Given this list of marker genes BAK1, DPYSL4, KRT7, PHF13, CCNA1 (cyclin A1), MFHAS1, WWOX, CFL1, HARS1, DTNB, CACNA1D, SEMA7A, CXCL9, ZNF112, CAPN2, FDX1, MYOF, PIAS3, PSMA5, PHGDH, SLC4A4, ACKR2, CYP1A1, MECP2, IFIT2, SLIRP, KDM5D, NAA30, GBE1, PRG2, RECQL5, NDUFS7, SRXN1, PSMB8, ANGPTL2, UNK, GPA33, CPLX4, IAH1, PARP12, CCNA2 (NCBI Gene Id 890), CHDH, ATF3, GUCD1, REPS1, KCNJ12, GDI2, BLOC1S5, DDIT3, SNRNP27, NSMF, EHBP1 (EH domain binding protein 1), CCDC71L, ST6GALNAC6, UBQLN2, SEMA3B, SLA2, DYNLT1, CD200, UQCRFS1, PHLDA2, NCOR1, LAT, ZBTB2, CYP27B1, TRIP11, KLHDC4, CNOT4, GATC, NECAB3, SCNN1A, IER3IP1, RFC2, RPS9, STAT5A, CCT2, PLXND1, RBM10, OSBPL11, RXRB, SOCS2, IREB2, LZTFL1, VRK2, C11orf68, IL10RB, IRF8, USP38 (NCBI Gene Id 84640), SYT9, COL4A2, MYD88, CX3CL1, ARHGAP35, EIF1B, IER5, ABCA2, ADIPOR2, DNAJC1, RP9, C19orf25, PTPRJ, SMOX, SPAG5 (sperm associated antigen 5), UBE2D2, GDNF, TBL1X, SLC30A1, MGA, SHFL, ZNF131, CDKN2A, TIPARP, LMNB2, DRAM2, ZNF605, ARSI, METAP2, TTC39C, ACTN1, CPSF2, FBXO11, PARK7, CTDNEP1, AUTS2, ATF6, MTARC2, IQSEC1, CRYAA, OGG1, BPGM, KIF21B, SFN, WASHC2A, TLN1, GAPDHS, OLR1, NID1, SUGP1, SLC28A2, PAGR1, TAF4, CLCN5, ARHGEF2, ADRB2, SATB2, ZMYM1, GPANK1, BSN (NCBI Gene Id 90068), RAP2A, DHX15, CEP250 (centrosomal protein 250), RPL12, MAFG, NPY1R, PAK1, PAPLN, TUT1 (NCBI Gene Id 64852), RARB, RAB31, SLC5A5, RBM42, ATP6V0A2, PALM, LANCL1, EHHADH, C6orf132, PANX1, ALDH1L1, CDPF1, CNPPD1, COPG2, LENG1, CALML3, THAP7, CRYBB2, PPP1R15A, CAPN7, EEF1AKMT1, SERPINE1 (serpin family E member 1), SUCLG2, GABRR1, METTL17, VCP, NDUFA13, MTDH, SLC6A15, DCX, DICER1, NUDC, EMP1, GON4L, APBB1IP, LYST, ATF5, TKT, LTBR, PHKG2, KCNN4 (NCBI Gene Id 3783), KCNK4, ZNF235, here is a description of the gene set: Human Gene Set: GSE17721_CPG_VS_GARDIQUIMOD_24H_BMDC_UP Genes up-regulated in comparison of dendritic cells (DC) stimulated with CpG DNA (TLR9 agonist) at 24 h versus DC cells stimulated with Gardiquimod (TLR7 agonist) at 24 h. from publication Amit I, Garber M, Chevrier N, Leite AP, Donner Y, Eisenhaure T, Guttman M, Grenier JK, Li W, Zuk O, Schubert LA, Birditt B, Shay T, Goren A, Zhang X, Smith Z, Deering R, McDonald RC, Cabili M, Bernstein BE, Rinn JL, Meissner A, Root DE, Hacohen N, Regev A (PMID 19729616) studied in species Homo sapiens mouse primary BMDCs were stimulated with tlr ligands and gene expression changes were profiled on Affymetrix arrays